Given this list of marker genes Atp1b2, Pam, Nup155, Slc8a1, Kdm3b (NCBI Gene Id 76106), Cacna1e, Hrk, Osbp2, Pkm, Snx15, Wdr46, Nfat5, Nrxn2, Kdm2b, Arf3, Man1c1, Klrd1, Creb3l2, Mettl26, Gm826, Zfp268, Tasor, Riok1, Vps25, Tfcp2l1, Mief1, Ctf2, Cbl, Nectin1, Prps1l3, Snap25, Ccnh, Lratd1, Cant1, Hip1, Prps1, Mpz, Polr1h, Gm11437, Slc26a2, Zfp984, Phex, Psd3, Actr3b (NCBI Gene Id 242894), Hecw1, Atp6v0d2, Brca2, Gigyf1, Ccn3, Usp17la, Klrb1c, Fbln5, D830030K20Rik, Sumo1, Appbp2, Brd8dc, Lif, Klf12, Kcnd1, Mmp14, Stim2, Phf8, Sox14 (NCBI Gene Id 20669), Mecp2, Pcdhb13, Plcd4, A1cf, Dcaf7, Khsrp, Noct, Trim30b, Hyou1, Fam81a, Gss, Dock3, Strada, Tapt1, Kat7, Bpifa3, Larp1, Npas4, C1qtnf1, Slc6a8, Cd300lg, Rnf217, Gnas, Col5a1, Tnrc6b, Zc3h7b, Nxph3, Pex26, Prok2, Krtap13-21 (NCBI Gene Id 69696), Ar, Creb5 (cAMP responsive element binding protein 5), Napg, Csn2, Gstm2, Pappa2, Tent4a, Tmem132e, Map4k2, Zfp609, Hsd3b4, Mex3a, Slco1a6, Elavl2, Aff1, Ago3, Cfap70, Zfp512, Cd164, Tlr4, Plekhf1, Ppp2r2a, Dgkk, Parp9, Ap3s2, Rdx, Lzts3, Trank1, Lce6a (NCBI Gene Id 78382), Mga, Rps6ka6, Fcho2 (FCH domain only 2), Ube2q2, AB124611, Ccdc71, Cpsf2, Zfp292, Elovl4, Prrc2b, Baiap2, Ap2m1, Det1, Nck2, Thrb, Lrig2, Adarb2, Hoxb9, Fgf13, Zfp936, Dusp10, Nhsl3, Pde5a, Rictor, Mgat4c (NCBI Gene Id 67569), Usp50, D16Ertd472e, Gpr12, Glcci1, Trim66, Sec63, Tmem168, Gtf2e1, Or10d5j, Fem1b, Mapre3, Chd3, Cpsf7, Ighmbp2, Arhgef9, Arcn1, Atf7 (activating transcription factor 7), Gnpda2, Orai2, Celf4, Ptbp3, Ubqlnl, Pik3cb, Dmgdh, Iws1, Chic2, Phf2, Pld5, Rgs8, Pla2g4c (NCBI Gene Id 52126), Cap1, Med13, Col5a3, Grm7, Gm10408, Kmt2a, Chtf8, Nefh, Cbx2, Edem2, Rcc2, Tox, AU018091, Grk4, Iqgap3, Mospd2, Hipk3, Hsd3b8, Ago1, Pappa, Pou2f3, Mlf2, Dock5, Esrrg, Tbc1d25, Sh3pxd2a, Strbp, Sprr2a2, 1700029H14Rik, Slc22a16, Aak1 (NCBI Gene Id 97341), Ttc39b, Srgap1, Fign, Col19a1, Maff, Gls, Itga4, Pea15a, Stat3, Mlph, Mdm4, Fjx1, Gripap1, Nlgn1, Elp3, Tshr (NCBI Gene Id 22095), Casp9, Dedd, Gprc5b, Sbk3, Prss3b, Clic5, Sprr2a1, Atp11c, Sestd1, Phf12, Pierce1, Xpr1, here is a description of the gene set: Mouse Gene Set: MIR_7683_3P species: Mus musculus from publication Chen Y, Wang X (PMID 31504780) Genes predicted to be targets of miRBase v22 microRNA mmu_miR_7683_3p in miRDB v6.0 with MirTarget v4 prediction scores > 80 (high confidence targets).